Given this list of marker genes Nde1, Plk1, Cenpu, Itgb3bp, Aurkb, Xpo1, Ppp2r5b, Dync1li2, Nup133, Cenpe, Cenpt, Ppp2r5a, Mis12, Ppp2r1b, Nup85, Seh1l, Ndc80, Ska1, Spc24, Mad1l1, Cenpm, Mad2l1, Ndel1, B9d2, Clasp1, Dynll1, Ppp2r5d, Kif2c, Cenps, Cenpq, Cenpn, Zwilch, Cenpa, Kif2b, Nudc, Kntc1, here is a description of the gene set: Reactome Pathway: Amplification of signal from the kinetochores This event has been computationally inferred from an event that has been demonstrated in another species.<p>The inference is based on the homology mapping from PANTHER. Briefly, reactions for which all involved PhysicalEntities (in input, output and catalyst) have a mapped orthologue/paralogue (for complexes at least 75% of components must have a mapping) are inferred to the other species. part of: Mitotic Spindle Checkpoint species: Mus musculus electronically inferred by orthology from the curated human pathway